The following is a description of a gene set: Neoplasm involving odontogenic cells, an odontogenic tumor. species: Homo sapiens Human Gene Set: HP_ODONTOGENIC_NEOPLASM Odontogenic neoplasm, and this is the list of marker genes: PTCH2, HSPG2, APC, OCRL, FGF3, SUFU, OFD1, PTCH1